Given this list of marker genes SNRPD3, PABPN1, NCBP1, CPSF7, SNRPG, SLBP, CLP1, NCBP2, PCF11, CPSF3, CPSF6, ZNF473, WDR33, SNRPF, CSTF1 (NCBI Gene Id 1477), SYMPK, FIP1L1, PAPOLA, NUDT21, CPSF2, SNRPE, CPSF4, CSTF2, LSM11, CPSF1, CSTF2T, CSTF3, SNRPB, LSM10, here is a description of the gene set: species: Homo sapiens part of: RNA Polymerase II Transcription Reactome Pathway: RNA Polymerase II Transcription Termination This section includes the cleavage of both polyadenylated and non-polyadenylated transcripts.<p> In the former case polyadenylation has to precede transcript cleavage, while in the latter case there is no polyadenylation.